The following is a description of a gene set: Relative coldness of a body part to palpitation, often acccompanied by feelings of coldness. Coldness Human Gene Set: HP_COLDNESS species: Homo sapiens, and this is the list of marker genes: NKX2-1, PAX8, TSHR, NKX2-5, SLC26A4, MECP2, FOXE1, CDKL5